The following is a description of a gene set: studied in species Homo sapiens Human Gene Set: MIR583 Genes predicted to be targets of miRBase v22 microRNA hsa-miR-583 in miRDB v6.0 with MirTarget v4 prediction scores > 80 (high confidence targets). from publication Chen Y, Wang X (PMID 31504780), and this is the list of marker genes: FSD1L, LACTB, CREB3L2, ELMOD2, SLMAP, MYLK3, FGF21, TFRC, TIAM1, RAB18, ARHGEF9, MXI1, SRD5A1, SIX4, CREBRF, ARID4A, SCML4, PURG, ZBTB20, ADAMTSL5, PCLO, WNK3, ZNF512, MED13, INAVA, KIT, SGO1, TRAPPC3, TUBGCP3, BPY2B, SLC25A27, CTTNBP2NL, DDX5, BDNF, SLITRK5, ANKRD46 (NCBI Gene Id 157567), SIVA1, RCAN2, DLG1, EPS15L1, ELAVL4, EPG5, PLAGL2, ELFN1, HRH4, GPR176, A1CF, SLC1A2, IRAG2, TMEM165, SEMA6A, BPY2, NUDT6, MMADHC, COG5, RAB7A, ZFYVE16, MMP16, LRRIQ1, PIK3R2, KCNK1, SH3TC2, ZNRF3, FGF23, PHC3, DGKI, IL23R (interleukin 23 receptor), ERBB4 (erb-b2 receptor tyrosine kinase 4), SLC38A9, HOXB2, FOXJ2, STRIP2, ARF6, YWHAH, GPR63, TRIM49, SPATS2 (NCBI Gene Id 65244), TFAP4, PWWP2B, NEDD8, NEFL, ERG28, PRRG4, PLS3, ATF7IP, PSME3, KLHL31, WNT11, C14orf28, MAB21L4, RPAP2, RASAL2, EN2, MED23, FOXC1, RIMS2, KCNK6, ZBTB18, ORC4, NXF2B, TRMT13, CAMK1D, ARB2A, ST8SIA3, PNN, RTP1, KAT6A, MIDEAS, SINHCAF, PHETA2, KCNA4, YIPF3, CDK15, MSI2, DUSP28, ERLIN1, GADL1, RAB10, ENTPD4, EIF4A2, RPGRIP1L, KPNA3, INPP1, GFRAL, TRA2A, IRF2BP1, ADA2, BPY2C, POLE3, BNIP3, CYP3A7, ZNF841, NXF2, NDRG1, SESN2, EXOC6B, SNX25, PTK2B, PA2G4, PCED1B, NUP98, STK39, PTBP3, PRPSAP2, TRIM49C, ENTPD1, GNAI3, NANP, TSN, NRG3, KCNRG, NAV1, SDE2, CCSAP, CACNA1E, CWC25, GLRX, IPMK, XPR1, CISH, APEX2, C3orf52, POU4F1, ZNF800, FBXW10B, C2orf76, C21orf91, APAF1, PPP3CA, SPCS3, CCAR2, USP34, APC, NWD1, JAK1, STOX1, RNF139, ARHGEF35, GABPB2, CDH12